Given this list of marker genes TIRAP, LGALS9, ANO6, RPL13A, HSD3B7, FCER1G, MOSPD2, ZNF580, MICOS10-NBL1, C5AR2, SFTPD, CCL3, PTPRJ, IL23A, CXCL12, AIF1, IL34, CXCL3, DUSP1, S100A12, TNFSF14, TNFAIP6, CCL26, VAV3, VEGFC, CCL23, KLRK1, DEFB124, IL6, ADAM10, CCR5, CKLF, CAMK1D, S100A7, MAPK1, CCL11, CXCL6, CCL1, NUP85, MAPK3, CCL25, NEDD9, TMEM102, NINJ1, ARHGEF5, GPR18, PF4, OXSR1, EDN1, LBP, CCL22, DPP4, NBL1, HMGB1, GPR15LG, MTUS1, CX3CR1 (NCBI Gene Id 2836), SLC8B1, CXCR2, MSTN, CXCL9, CXCL8, S100A8, CCR1, CALCA, CNR2, PF4V1, JAM3, CCL4, FOLR2, MMP2, GREM1, PTPRO, CCL5, SRP54 (NCBI Gene Id 6729), RARRES2, CCR7, VEGFA, SBDS, RAC2, PREX1, CSF3R, THBS1, S1PR1, SLIT2, TREM1, PIP5K1C, IL17RC, CALR, XCL1, FLT1, CXADR, DEFA1B, TRPM2, CXCL11, IL17RA, EDN3, PIK3CG, PPIB (peptidylprolyl isomerase B), PERP, PDE4B, CCL4L2, PDGFB, CORO1A, CCL8, MDK, TGFB2 (NCBI Gene Id 7042), MSMP, CREB3, PTK2B, SLAMF1, GAS6, RIPOR2, ADAM8, PPBP, RAC1, CCL24, GBF1, VAV1, ADAM17, CCL16, CXCL17, CXCL16, CXCR5, ADGRE2, S100A14, C1QBP, ANXA1, KIT, CXCL13, WNK1, WNT5A, F2RL1, PLEC, MPP1, VEGFB, PTK2, LYST, CX3CL1, RPS19, SPI1, FPR2, CD300H, AZU1, CYP7B1, VEGFD, LYN, APP, CCL21, PIKFYVE, CCR6, RIN3, STK39, DEFB104B, CCR2, IL16, PTN, MIF, PIK3CD, PGF, PADI2, SCG2, GPR183, MCU, TNFSF11, EDNRB, KLRC4-KLRK1, CCL7, C5AR1, CCL27, LGMN, DEFB104A, DEFB131A, CSF1R, DAPK2 (death associated protein kinase 2), CXCR3 (C-X-C motif chemokine receptor 3), ITGA9, C3AR1, IL6R, TRPV4, CCN3, CCL13, DEFA4, CXCR4, NCKAP1L, EDN2, MMP28, DNM1L, ALOX5, BST1, CYP19A1, BSG, PLA2G1B, CCL2, SYK, SERPINE1, IL1B, IL12A, PLA2G7, SLAMF8, TAFA4, TNFRSF11A, C5, CMKLR1, F7, DEFA1, CCL19, SAA1, S100A9, CHGA, IL10, AKIRIN1, DDT, CTSG, GPSM3, STAP1, THBS4, CH25H, PPIA, CSF1, TNFSF18, CXCL5, ITGA1, ITGB2, SWAP70, LGALS3, CXCL10, SLC12A2, TRPM4, CD74, CXCR1, CCL28, FFAR2, DPEP1, JAML, MIR223, here is a description of the gene set: studied in species Homo sapiens Human Gene Set: GOBP_LEUKOCYTE_CHEMOTAXIS The movement of a leukocyte in response to an external stimulus.